The following is a description of a gene set: studied in species Homo sapiens Mitochondrial unfolded protein response (UPRmt) Human Gene Set: REACTOME_MITOCHONDRIAL_UNFOLDED_PROTEIN_RESPONSE_UPRMT, and this is the list of marker genes: SOD2, HSPA1A, HSPD1 (NCBI Gene Id 56733), HSPA1B, HSPE1, AKT1, CAT (catalase), SIRT3, NRF1, DEFA5, HTRA2, HSPA9, ATF5, DNAJA1, FOXO3, LONP1, ESR1, HSF1